Given this list of marker genes Wdr33, Ppp1r1c, Tcf7l2, Plaat3, Gabrb3, Or51ab3, Stum, Zfp729a, Eif4enif1, Gnaq, Arpp21 (NCBI Gene Id 94243), Lcorl, Oprd1, Zfp970, Lamp2, Heyl, Il21, 6030458C11Rik, Gpatch8, Rfx3, Zfp26, Samt4, Gria4, Pfkfb2, Zbtb43, Wsb1, Brinp1, Snurf, Naa11, Dusp7, Pank3, Mrgpre, Slc12a1, Hivep1, Evi2b, Dusp16, Ro60, Gm94, Oxgr1, Snrpn, Or12j5 (NCBI Gene Id 258513), Pcdh10, Cdk8, Hecw1, Ano4, Ypel5, Fgf7, Htr3b, Ldb3 (NCBI Gene Id 432840), Jhy, Xrcc3, Extl3, Zfp831, 4930444P10Rik, Steap2, Fancd2os, Cdc23, Cemip (cell migration inducing protein, hyaluronan binding), Ccpg1, Slc35d2, Csnk2a2, Atrn, Pstpip2, Cimip2b, Clrn1, Ids, Brwd3, Nrxn1, Insm1, Slc5a8, Riox2, Cacna1g, Il18r1, Zfp729b (NCBI Gene Id 380856), Sim1, Kcnj3, Ptbp3, Csf2rb2, Cplx2, Cep295, Gadl1, Car5b, Epyc, Foxc1, Dclre1c, Spef2, Prokr2, Zfp1009, Nxpe3, Col4a5, Olfm3, Zfp945, Lrrn4cl, Fmn2, Ifi202b, Cdc73, Ptprk, Trub2, Usp25, Epc1, Wdr82, Ago3, Zfp967, Myo9a, Amotl1, Aldh1l2, Sarnp, Crebrf, Fech, Kras, Tfap2b, Ell2, Dnm3, Zfp966, Pank1, Bcl2, Arhgef33, Glcci1, Tasor2, Slco3a1, Prr11, Elapor2, Serp1, Serpinb1a, Rnf220, Clec5a, Kcnab2, F830016B08Rik, Cyria, Camta1, Galnt12 (NCBI Gene Id 230145), Nsd2, Zfx, Lrch1, Rab7, Tomt, Dpp4, Sorcs3, Spn, Tbc1d24, D630023F18Rik, Papss2, Ntrk3, Gm12253, Manea, Azin1, Smoc2, Cdh11, Tnfsf15, Ice1, Vwc2, Acot8, Arhgap25, Cpsf2, Itgb1bp1, Pramel22, Pramel27, Acer3, Sfi1, Crppa, Cops2, Gbp4, Ppp6r2, Homer1, Heph, Bltp3b, Abraxas1, Rock2, here is a description of the gene set: from publication Chen Y, Wang X (PMID 31504780) studied in species Mus musculus Genes predicted to be targets of miRBase v22 microRNA mmu_miR_297b_5p in miRDB v6.0 with MirTarget v4 prediction scores > 80 (high confidence targets). Mouse Gene Set: MIR_297B_5P